The following is a description of a gene set: studied in species Mus musculus The propagation of an action potential along the plane of an excitable membrane. Action potentials typically propagate once triggered because the depolarization of adjacent membrane regions due to an action potential crosses the firing threshold. Mouse Gene Set: GOBP_ACTION_POTENTIAL_PROPAGATION, and this is the list of marker genes: Fkbp1b, Cldn19, Cacnb4, Pmp22, Ntrk3 (NCBI Gene Id 414121), Clcn1 (NCBI Gene Id 232740), Ntrk2, Cntnap1, Nrcam (NCBI Gene Id 77467), Scn1a, Scn9a, Scn1b, Atp1a2